Given this list of marker genes OGG1, here is a description of the gene set: part of: Diseases of Base Excision Repair species: Homo sapiens Reactome Pathway: Defective Base Excision Repair Associated with OGG1 OGG1 is the main DNA glycosylase responsible for removal of 8-oxoguanine (8oxoG), the most frequent type of oxidative DNA damage, from DNA and initiation of the base excision repair. A frequent OGG1 polymorphism increases the risk of breast and lung cancer in affected individuals, and inactivating mutations in OGG1 have been reported in various cancer types and in Alzheimer's disease. Ogg1 knockout mice are predisposed to cancer. For review, please refer to Boiteux et al. 2017.